Given this list of marker genes Abcc2, Cox15, Hmbs, Alas1, Urod, Slco2b1, Alad, Alb, Ugt1a1, Hmox1, Gsta13, Gsta3, Blvra, Cpox, Gsta5, Cox10, Alas2, Fabp1 (fatty acid binding protein 1, liver), Ugt1a5, Hmox2, Slco1b2, Fech, Ppox, Ugt1a2, Gsta1, Uros, Flvcr1, Gsta2 (NCBI Gene Id 14858), Abcc1, Blvrb, here is a description of the gene set: Mouse Gene Set: REACTOME_METABOLISM_OF_PORPHYRINS studied in species Mus musculus Metabolism of porphyrins